The following is a description of a gene set: Regulation of mRNA stability by proteins that bind AU-rich elements species: Homo sapiens Human Gene Set: REACTOME_REGULATION_OF_MRNA_STABILITY_BY_PROTEINS_THAT_BIND_AU_RICH_ELEMENTS, and this is the list of marker genes: PSMD11, DCP1A, PSMB2, HSPB1, ELAVL1, PSMC1, PSMA1, PSMD7, YWHAZ, PABPC1, HNRNPD, ZFP36L1, PSMB6, PSMA7, EXOSC6, EXOSC8, NUP214, PSMD6, MAPK11, PSMD8, XRN1, PSMD2, PSMA3, PARN, PSMB3, TNFSF13, HSPA8, DIS3, TNPO1, MAPKAPK2 (NCBI Gene Id 9261), PSMC4, EXOSC4, EXOSC3, YWHAB, EXOSC9, PSMD1, ANP32A (NCBI Gene Id 8125), UBB, PSMC2, HSPA1A, XPO1, EXOSC5, EXOSC2, ZFP36, PSMB7, PSMD3, PSMC6, PSMA6, RPS27A (NCBI Gene Id 6233), MAPK14, SEM1, DCP2, PSMB5, PSMD12, PSMA5, PSMB4, AKT1, UBA52, PRKCA, PSMD13, PSMD14, PSMB1, EXOSC1, ADRM1, SET, EIF4G1, PRKCD, PSMA4, PSMA2, PSMC3, EXOSC7, UBC, PSMC5, KHSRP